The following is a description of a gene set: from publication Napolitani G, Rinaldi A, Bertoni F, Sallusto F, Lanzavecchia A (PMID 15995707) Human Gene Set: GSE2706_LPS_VS_R848_AND_LPS_2H_STIM_DC_DN Toll like receptors (TLRs) sense microbial products and initiate adaptive immune responses by activating dendritic cells (DCs). Since pathogens may contain several agonists we asked whether different TLRs may synergize in DC activation. We report that in human and mouse DC TLR3 or TLR4 potently synergize with TLR7, TLR8 or TLR9 in the induction of selected cytokine genes. Upon synergistic stimulation, IL-12, IL-23 and Delta-4 are induced at levels 50-100 fold higher than those induced by optimal concentrations of single agonists, leading to enhanced and sustained TH1 polarizing capacity. Using microarray analysis we show that only 1.5% of the transcripts induced by single TLR agonists are synergistically regulated by combinations of TLR4 and TLR8 agonists. These results identify a combinatorial code by which DCs discriminate pathogens and provide (suggest) a rationale to design adjuvants for TH1 responses. Series_overall_design: 3 untreated, 3 treated with LPS at 2h, 3 treated with LPS at 8h, 3 treated with R848 at 2h, 3 treated with R848 at 8h, 3 treated with LPS + R848 at 2h, 3 treated with LPS + R848 at 8h Genes down-regulated in comparison of dendritic cells (DC) stimulated with LPS (TLR4 agonist) at 2 h versus DCs stimulated with LPS (TLR4 agonist) and R848 for 2 h. species: Homo sapiens, and this is the list of marker genes: TTYH2, PTOV1-AS1, LINC00663, USP11, TOB1-AS1, GPIHBP1, NKX2-3, DNAH17, SEMA5B, TJP1, KIF20A, DNAAF8, ACVR1C, CACNG1 (calcium voltage-gated channel auxiliary subunit gamma 1), SOX9, RGS2, CRIP1, ZNF571, MBL2, EDN1, BEND7, TNFRSF13B, PHETA2, ZNF836, HGFAC, FAM43B, GPRC5C, MT4, TUBB2A, EGR1 (NCBI Gene Id 1958, early growth response 1), MACROD2, GNAT1, CCK, KRTAP17-1, TJP2, MGAM, PAK6-AS1, ZNRF2P1, GLIS3-AS1, TCF7L2, LPAL2, PGK2 (phosphoglycerate kinase 2), PCP4, IL9R, SLC35D3, TAS2R13, CD300LG, CDKN2B, RPS2P45, PLXNC1, STAT4, TNFSF15 (NCBI Gene Id 9966), GHRH, TOP6BL, SLC32A1, GPR83, FXYD6, IL12B, ZNF79, MAGEE1 (NCBI Gene Id 57692), SIGLEC11, CYP21A2, ESRP1, DCHS2, CHRNB4, FSD1L, WFDC21P, DELEC1, CYP27B1, LINC00942, CLUHP3, CLPS, SPATA3-AS1, SLC16A11, KMO, LINC01356, CDCA4, DGKE, CILP2, PLEKHH3, TEKT3, PNOC, NABP1, ZIC2, SRPX2, TPO (NCBI Gene Id 7173), IGSF9B, SP2-AS1, TSPY1, LRP11, SERPINB9, BHLHE22, TMEM132C, TEX55, SLC14A1, FNDC1, GVQW3, CDC42BPG, CFTR, GRASLND (NCBI Gene Id 386597), CALHM3, LINC00926, SYCE3, ADCY10P1, SMIM1, KIAA1210, RAB3IP, LINC00311, APOA4, EML5, LINC00242, SLC1A3, TTC39A, MSH4, MIR7-3HG, PDE2A, FLACC1, DHFRP3, ANKS4B, OR7A5, FOXG1, CHEK1 (checkpoint kinase 1), SHMT1, SLC6A14, ANKRD19P, ID4, SMG6, IZUMO2, KRT19, TMEM217, TMPRSS11E, RLBP1, MYH7B, NPHP4, TRAF4, MARCKSL1, KIAA1586, HOXD13, CYRIA, DNMT3L, UST-AS1, FNBP4, TAGAP, NUP210L, C14orf178, CLEC14A, CYP2C8, LINC01968, ATXN8OS, TRIM36, ASIC5, BCL2A1, TMOD4, GAS2L2, ZYG11A, GPRASP1, H2AC17, CECR7, PUS10, DLGAP1, LRRC3, FRMPD3, TAS1R2, RTL3, OIT3, LINC01118 (long intergenic non-protein coding RNA 1118), CLDN1, NPFF, EVX1, ENSG00000248540, NETO1, WASF1, PPIEL, FOXM1, LENEP, TLX3, MDH1B, DMRTC2, IGSF21, ERICH3, NDOR1